The following is a description of a gene set: studied in species Homo sapiens Synthesis of 12-eicosatetraenoic acid derivatives Human Gene Set: REACTOME_SYNTHESIS_OF_12_EICOSATETRAENOIC_ACID_DERIVATIVES, and this is the list of marker genes: GPX2, ALOXE3, ALOX15, ALOX12B, ALOX12, GPX1, GPX4